Given this list of marker genes Paf1, Ctr9, Nanog, Sox2, Leo1, Hnf1b, Pou5f1, Gata6, Rtf1, Mesp1, Sox17, Cdc73, Eomes, Dkk1, Ctnnb1, here is a description of the gene set: The cell differentiation process that results in commitment of a cell to become part of the endoderm. studied in species Mus musculus Mouse Gene Set: GOBP_ENDODERMAL_CELL_FATE_COMMITMENT